The following is a description of a gene set: Any process that modulates the rate or extent of heart growth. Heart growth is the increase in size or mass of the heart. studied in species Mus musculus Mouse Gene Set: GOBP_REGULATION_OF_HEART_GROWTH, and this is the list of marker genes: Nr3c1, Myh6, Mir1a-2, Cxadr, Sav1, Wt1, Fgf20, Cited2, Nog, Bmp10, Ep300, Mapk14, Wnt2, Prox1 (NCBI Gene Id 320240), Sirt1 (sirtuin 1), Trip10, Gsk3a, Tbx20, Pten, Zfp418, Yy1, Gata6, G6pd2, Pin1rt1, Jarid2, Parp2, Yap1, Col14a1, Kcnk2, Nrg1, Ccnd2, Fgfr2, Tgfbr3, Ahr (NCBI Gene Id 193333), Rbp4, Cdk1 (cyclin dependent kinase 1), Slc25a4, Apc, Hdac2, Ppara, Ctdp1, Tbx1, Bmpr1a, Tbx5, Pak1, Cav3, Mtor, Foxp1, Rbm10, Mir208a, Mapk1, Zfpm2 (NCBI Gene Id 320725), Dusp6, Tgfbr2, Hey2, Nkx2-5, Trp73, Mef2c, Vgll4, Acacb, Fdps, Adrb1, Rgs4, Gja1, Rbpj, Fgf9, Dyrk1a, Fgf2, Mir133a-2, Pi16, Erbb4, Gli1, Ccn4, Pin1, Gata4, Tbx2, Ncam1, Akap6, Rgs2, Igf1, Mapk11, Ccnb1, Notch1, Edn1, Tgfbr1, Mir133a-1, Tomm70a, Ddx39b, Pim1, Hamp2, Hamp, Fgfr1, G6pdx (NCBI Gene Id 14381)